The following is a description of a gene set: from publication Zak DE, Andersen-Nissen E, Peterson ER, Sato A, Hamilton MK, Borgerding J, Krishnamurty AT, Chang JT, Adams DJ, Hensley TR, Salter AI, Morgan CA, Duerr AC, De Rosa SC, Aderem A, McElrath MJ (PMID 23151505) studied in species Homo sapiens To better understand how innate immune responses to vaccination can lead to lasting protective immunity, we used a systems approach to define immune signatures in humans over 1 wk following MRKAd5/HIV vaccination that predicted subsequent HIV-specific T-cell responses. Within 24 h, striking increases in peripheral blood mononuclear cell gene expression associated with inflammation, IFN response, and myeloid cell trafficking occurred, and lymphocyte-specific transcripts decreased. These alterations were corroborated by marked serum inflammatory cytokine elevations and egress of circulating lymphocytes. Responses of vaccinees with preexisting adenovirus serotype 5 (Ad5) neutralizing antibodies were strongly attenuated, suggesting that enhanced HIV acquisition in Ad5-seropositive subgroups in the Step Study may relate to the lack of appropriate innate activation rather than to increased systemic immune activation. Importantly, patterns of chemoattractant cytokine responses at 24 h and alterations in 209 peripheral blood mononuclear cell transcripts at 72 h were predictive of subsequent induction and magnitude of HIV-specific CD8(+) T-cell responses. This systems approach provides a framework to compare innate responses induced by vectors, as shown here by contrasting the more rapid, robust response to MRKAd5/HIV with that to yellow fever vaccine. When applied iteratively, the findings may permit selection of HIV vaccine candidates eliciting innate immune response profiles more likely to drive HIV protective immunity. Human Gene Set: ZAK_PBMC_MRKAD5_HIV_1_GAG_POL_NEF_AGE_20_50YO_1DY_UP Genes up-regulated in peripheral blood mononuclear cell 1d vs 0d in adults (20-50) after exposure to MRKAd5 HIV-1 gag/pol/nef, time point 1D. Comment: Table includes specific cell types, and this is the list of marker genes: BCKDK, BAZ1A, DIAPH2, PDLIM5, MYOF, NANS, CLEC6A, GASK1B, RNASEL (NCBI Gene Id 6041), XKR8, NLRC4, GBP3, CORO1B, CPNE8, PRRG4, TAPBP, SLC1A5, MXD1, C5orf15, CLIC1, CCL2 (NCBI Gene Id 6347), SIPA1L1, CEACAM1, LRRC59, KRTAP4-7, CYBB, CUL1, TYROBP, PLIN3, SIL1, NAT8B, GCNT1, TMEM150B, GALNT3, PLA2G7, IFI27 (NCBI Gene Id 3429), RHOB, TAP1, GCH1, ARL8A, STAB1, RIN1, GDPD5, DOK3, CPEB3, TTYH3, ALAS1, SNTB1, UTRN, TLR1, RTP4, ATG3, FUOM (fucose mutarotase), CSRNP1, LYST, SP100, SRC, HCAR3, OAS3, TRIM38, ALOX5, ITPRIPL2, OGFR, CLCN7, MSR1, KSR1, EPB41L3, NAIP, NHLRC3, RNF217 (NCBI Gene Id 154214), TBK1, SOCS1, BATF2, TNFSF13, GNB2, TMEM140, OLFM4, SPPL2A, SIRPD, NT5C3A, TATDN3, SPTLC2, TCN2, CLEC12A, B4GALT5, MFSD2A, KCNJ15, TASL, SMCO4, ADAM17, AGTRAP, JUP, FERMT3, RIPK3, AKR1A1, RNFT1, AP5B1, MIR223, FOLR2, FAS, RASGRP3, NAPRT, NAGK, ATP6V0D1, STAT5A (NCBI Gene Id 6776), SLC22A15, VTA1, ZMIZ1, KLF4, RASSF4, FXYD6, BACH1, DHRS7B, TANK, CHST15, PRKCE, TMEM131L, NUCB1, EMILIN2, SLC29A1, LGALS3BP, FCN1, CAPZA2, SIRPB2, ATP2A2, ABI3, RBBP8, SQOR, PPM1K, SLC35F6, SIGLEC9, SNX20, LY6E, TMEM175, EIF4E3, PSENEN, ATP8B4, QSOX1, SORT1, ADPRS (ADP-ribosylserine hydrolase), ABCA1, HLA-DPA1, PFKFB3, CES1, CD86, SPATS2L, SEC24D, RAB10, CXCL11, CLEC4D, MRPL44, FAM111A, FGD4, ARSA, P2RY13, RTCB, PELI1, MT2A, ATOSB, ADGRE2, C1QB, DUSP5, PTPA, SLC11A1, PSMB9, STARD8, LILRB2, P2RY6, GMPPA, CASP7, STXBP2, AQP9, MIR22HG, STS, TP53I3, ADPGK, GBP1, GMPR, EHBP1L1, GLMP, ADM, P2RY12, PARP10, FNIP2, IL27, ZFYVE26, NBN (nibrin), EIF4E2 (eukaryotic translation initiation factor 4E family member 2), PLEKHO2, LAT2, PRDX3, CTNNA1, GAA, NUBP1, FGR, CAMK2D, MFSD14B, DNASE1L1, RARA, TNFAIP8L2, TRIM22, ATP13A1, GPR35, MASTL, TMEM176A, GRAMD1B, CD300A, MICAL1, SAT2, EXOC1, CYSTM1, SCO2, RBCK1, ABCD1, HCAR2, MSRB1, IL10, HSPA6 (NCBI Gene Id 3310), ZSWIM6, LILRA6, LMO2, ABHD16A (NCBI Gene Id 7920), CD300E, FPR3, CLEC7A, C5AR1, USP30-AS1, CMKLR1, FLVCR2, CMIP, CXCL10, P2RX4, TJP2, SAMD9L, CD40, IFIT1, LACTB, HLX, NPC2 (NCBI Gene Id 10577), SLC27A3, GBA1, MYD88, ADAM9, HCK, RNF13, SLC25A24, SLC15A3, FNDC3B, GLIPR2, ERLIN1, MICB, IFITM3, FAR2, CEACAM3, CHMP5, FAM91A1, MIR221, KIAA1958, TAGLN, IFITM1, REEP4, DPYSL2, METRNL, CALHM6, UBE2L6, IL15, ATP1B3, LGALS9B, MIDN, GLB1, TLR7, GLT1D1, PTPRE, SLFN11, PEAK3, SLC9A9, CHST12, LOXL3, ATF5, IDO1, SIGLEC1, TNFRSF1B, S100A11, ANKFY1, BST2, NQO2, CD300LB, IDH1, AGPAT3, MEFV, HGF, CSRP1, EFHD2, TGM2, RXRA, FPR1 (formyl peptide receptor 1), MSRB2, PLXDC2, ZFP36, SIGLEC5, YIPF1, HP, SLFN12, CMTR1, LTF, HLA-DMB, IGSF6, PLAGL2, DTX3L, ACOT9, SLC38A5, TBC1D8, LIMK1, ELMO2, MCTP1, PSTPIP2, CYSLTR2, MS4A4A, CPPED1, SLC24A4, C1orf162, CGAS, AZI2, TIFA, SCPEP1, MBOAT7 (NCBI Gene Id 79143), RAB20, DNAJA1, NFKBIE, FAM151B, RGL1, LILRA2, ANKRD22, LRRK1, TRIM5, ICAM1, C2, SAMD9, CFB, GNS, SLC2A6, PMVK, BCL2A1 (NCBI Gene Id 597), ST8SIA4, CPED1, GTPBP1, GBP2, WIPI1 (WD repeat domain, phosphoinositide interacting 1), MPDU1, WDR41, IFITM2, UBA3, PIM3, CASP1, RIGI, ADAMTSL4, ACSL3, CSF2RB, SLC8A1, NETO2, SLC31A2, PAM, GIMAP8, USP6NL, SLC16A3, KIAA0319L, ST14, RENBP, CYBA, IFIT3, SDHB, MRPL28, ITPK1, TCIRG1, IFIH1, SLC37A1, ATP6V1B2, SLC39A1, FGD6, STIMATE, C11orf24, POMP, MOSPD2, APOBR, RRAGC, ARHGEF11, HLA-DMA, HPSE, MBOAT1, SH2B2, GRK3, MS4A6A, DOCK5, SUOX, RAB12, NFIL3, PIGS, LRRC25, CTNND1, RAB4B, ANKRD34C-AS1, PEA15, SBNO2, IFI30, DHX58, LAIR1, CASP4, RNPEP, NOP10, CALCOCO2, PARP12, APOL2, RUBCN, PLSCR1, PILRA (paired immunoglobin like type 2 receptor alpha), S100A9, ANXA4, SERPING1, OAS1, ASPHD2, ARHGAP31, LILRB3, LPCAT2, RAB24, PLEKHO1, RIC1, CST3, PGK1, TOR4A, ECE1, SIDT2, DUSP18, NR1H2, DSE, TAP2, EHD4, SLC6A12, TLR2, SECTM1, RPS6KC1, NID1, GK3, AGRN, NCSTN, STAT3, ELF4, MVP, TRANK1, ADPRH, SLC15A4, SP110, MLKL, KLHDC7B, FFAR2, RNH1, LMNB1, MAFB, ACP3, ETV6, XRCC4, IGLV4-69, NLRP3, FCGR2A, GADD45B, RNF31, SP140, ANXA2, PLAUR, CD300LF, NTNG2, EPSTI1, KYNU, DECR1, MERTK, MTF1, TRIB1, CTSZ, MARCKS, KDM1B, APOL3, WDFY3, PDCD1LG2, SRGAP2, NUP62, LHFPL2, EDEM2, PLA2G15, HEG1, MX1, SLC43A3, CSF1R, TOP1, NADK, H2BC21, CLEC5A, SLAMF8, DNPEP, DDX60L (DExD/H-box 60 like), LRRK2, GYG1, HSH2D, SRA1, IRF9, CTSD, TRIM25, ABTB2 (ankyrin repeat and BTB domain containing 2), TMEM106A, NINJ1, KIAA0513, ETV7, MAP3K11, HERC6, ZBP1, TIGAR, ZNF438, APOL1, CDKN1C, ACER3, HAVCR2, ARHGAP27, CTBS, TMEM176B, PTTG1IP, SMAD1, NMI (N-myc and STAT interactor), FGD2, PATL1, ATP6V1C1, CNDP2, SIGLEC7, LAMP2, KIAA0040, ORMDL2, SERPINA1 (serpin family A member 1), HMGCS1, IFIT5, VDR, MRPL27, LINC01504, ASCL2, KCTD12, USP15, CDC42EP2, BEST1, PSMA4, P2RY2, BLOC1S1, PRKCD, STK3, KMO (NCBI Gene Id 8564), FMNL2, CD36, PLAAT4, SHFL, BST1, BCL6, TREX1, MAP3K7CL, LILRA3, MTHFD2, NAPA, SH3BP2, DENND5A, GCA, LAMP3, OASL, RTL5, PSMB10, FUCA2, DYNLT1, RASGRP4, LST1, WSB1, GOLM1, SLC7A7, IRF7, HAPLN3, GPR141, TRIM14, STOM, USP25, ALYREF, GPD2, TIMP1, CEBPB, SLC20A1 (solute carrier family 20 member 1), GAS6, USF1, CD38 (CD38 molecule), GPBAR1, SLC37A2, GRN, RNF149, FES, FBXO6, TUT7, MT1E, UBC, GTPBP2, CIR1, PSEN2, CNIH4, TMEM179B, SDC3, NAGA, ZNFX1, MCOLN1, RCBTB2, SPI1, HERC5, IL15RA, RIPK2 (receptor interacting serine/threonine kinase 2), TNS3, DMXL2, CASP10, PTGIR, SKAP2, VAMP3, IGF2BP3, MS4A14, OAS2, KPTN, SLC25A28, GPR84, BTK, NPL, MIRLET7D, ARSB, RAB1A, CD163, USP32, TENT5A, PML, TLR8, RSAD2, SLC31A1, PNPT1, STARD4 (NCBI Gene Id 154899), GDAP1, NOD2, TRAFD1, DOK1, TOR1B, SIRPB1, RBM47, MOV10, IL1RN, EMP3, E2F2, KDM7A, NRROS, STYXL1, IFI44, PYCARD, SIPA1L2, IFIT2, TMEM229B, ARHGAP17, SHKBP1, C3AR1, GLRX, LRRC4, CASP3, STAC3, RNASE2, CARD6, SNX2, SIGLEC14, SBF2, PARP9, PARP11, CYFIP1, EXT1, MICU1, SOCS3, ASGR2, LTBR, ATP1B1, C3orf38, RAB8A, CHMP2A, ZCCHC2, H1-0, BAK1, CTSL (NCBI Gene Id 1514), AOAH, MIA3, TET3, PSMA6, LILRB4, EMC2, RIN2, ATP11A, XAF1, LPAR1, IFI35, ACSL1, STAT2, FCER1G, RAB39A, PLEK, SNX27, LDLR, NLN, EXOC6, LMF2, NR1H3, CCL8, ATG7, BLZF1, USP41P, CD2AP, ANXA5, PCMT1, ADA2, FPR2, TBC1D2, ST3GAL5, MPZL2, GRINA, MNDA, CARS2, NCF4, HMOX1, HLA-DRB5, MED20, LGALS9, TMEM255A, PRXL2C, APOL6, NT5C2, SLC16A6, ZDHHC11B, RUFY4, SNCA, DRAP1, FGL2, KIAA0930 (NCBI Gene Id 50610), TRPV4, SQLE, CAMK1, WDFY1, GPAT3, PSMB8, CLP1, PSME1 (NCBI Gene Id 5720), HRH2, LARP7, TMEM268, LPCAT3, HK3, BLVRA, DICER1, CD33, PELATON, PCTP, CCL3, POLK, NFE2, SERPINB8, ACTA2 (NCBI Gene Id 59), PACSIN2, ATF3, NHSL2, SSB, CMPK2, SLAMF7, TFEC, LYSMD2, DYSF, AXL, TNFRSF14, RILPL2, N4BP1, TNFSF13B, CBR1, KCNJ2, TIMP2, PLXNB2 (plexin B2), NFE2L3, HHEX, AATBC, DDB2, GBP5, PLXNC1, PFKFB4, SLC38A7, MILR1, IFI44L, RNF114, MVB12A, CXCL16, GIMAP6, DHRS9, ISG20, ETFDH, RP2, POLB, KCNMB1, BID, OTOF, NOD1, CDKN1A, GSDMD, CD300C, XRN1, DCUN1D3, CHD1, CIMAP1B, UNC93B1, GBP4, ARSD, JAK2, CCR2, ADAP2, CD63, CD274, SHISA5, SLC35A5, BATF3, CFP, GNB4, NECTIN2, DUSP3, NOTCH2, LAP3, IGF2BP2 (insulin like growth factor 2 mRNA binding protein 2), TNFSF10, DAPP1, VAMP5, CARD16 (caspase recruitment domain family member 16), FCAR, SMCHD1, NEXN, NEU1, ACSL4, MCEMP1, CD68, MFSD12, ALPK1, VCPIP1, IGFLR1, G6PD, TNFAIP2, MT1B, STAT1, LIMK2, DENND1A, STX11, RELT, SIRPA, TTC7A, RNF213, GNA15, DCBLD1, PSME2, DDX60, STX3, EFR3A, CTSB, C4orf33, IFNGR2, WAS, NCF2, SHTN1, VRK2, TYMP, GIMAP4, MIR21, TLR4, TRIM21, SUSD1, C9orf72, DIPK2A, THEMIS2, GK, IRF5, SCLT1, DRAM1, CNP, KIR2DL4, PTPRO, HLA-DRA, KCTD14 (NCBI Gene Id 65987), ADGRE5, PPIF, SEC14L1, PAK1, ISG15, GLUL, OSCAR, CREG1, CCR1, EIF2AK2, MFSD13A, PI4K2B (NCBI Gene Id 55300), CSF3R, NUB1, SPOPL, RAB31, RNF19B, IRF1 (NCBI Gene Id 96501), STX12, GUCY1A1, SRGAP2B, TCF7L2, RRAS, NECAP1, TUBA1A, TNFAIP6, UBA7, HLA-DRB1, TDRD7, PLAC8, CREB5, CASP5, TMPPE, MS4A7, GSTO1, C1QC, SLC49A3, TFE3, CAPG, DUSP6, RAPGEF2, RHBDF2, MX2, IFI6, MR1, GM2A, CYP51A1, PRELID1, ACP2, CD14, ADAR, CYRIA, RNASET2, RALB, P2RX7, SNX10, PHF11, RASGEF1B, ZEB2, STAM2, FKBP15, TNS1, ACSS2, WARS1, SEMA4A, IFI16, C15orf39, SASH1, RABGGTA, SLC22A4, CARINH, ZNF267, PIK3AP1, TRIM26, AIM2, SAT1, RB1 (RB transcriptional corepressor 1), NFAM1, BAG1, SLC43A2, LILRA1, UBE2D1, ROGDI, SNX11, PARP14, SDSL, SERPINB9, NAMPT, RNF135, TPMT, RUFY3, SH3RF1, STING1, MIIP, USP18, HK2, GORASP1, MMP8, IL4I1, SH2B3, SAMD4A, GNG5, SLC39A11 (solute carrier family 39 member 11), SCARB2, LYN, TLR6, SCIMP, CCRL2, ATOX1, HELZ2, NAAA, EPHB2, AKIRIN2, FAM225A, APOL4, CALML4, IL12RB1, DNAJC13, LILRA5, CFD, FRMD3, CD151, NRIP1, TAPBPL, IRF2, GALNS, MARCO, LILRB1